Given this list of marker genes UBE2D1, ANAPC7, ANAPC16, ANAPC1, ANAPC11, UBB, ANAPC5, CDC27, UBC, CDK1, UBA52, ANAPC10, CDC16, RPS27A, UBE2C, CCNB1, CDC20, CDC23 (cell division cycle 23), ANAPC4, ANAPC15, ANAPC2, CDC26, UBE2E1, UBE2S, here is a description of the gene set: Reactome Pathway: APC/C:Cdc20 mediated degradation of Cyclin B studied in species Homo sapiens part of: APC/C:Cdc20 mediated degradation of mitotic proteins The degradation of cyclin B1, which appears to occur at the mitotic spindle, is delayed until the metaphase /anaphase transition by the spindle assembly checkpoint and is required in order for sister chromatids to separate.